Given this list of marker genes Nampt, Ralgapa1, Epha7, Pde6a, Zfp110, Icmt, Rhebl1, Stard8, Egf, Klk1b4, Arhgef3, Tlr2, Hesx1, Cxcl12, Ghrhr, Spag9, Flot2, Fbxo21, Ccl19-ps1, Dcn, Cysltr2, Taok3, Trim25, Hmga1, Gpr39, Fgd4, Ahr, Map3k10, Rock1, Tlr13, Fam83d, Gbp7, Rhov (ras homolog family member V), Myo9b, Mapk8, Fermt2, Trim55, Gbf1, Git1, Trim8, Capn1, Dock10, Cadm4, Usp25, Dnm2 (dynamin 2), Rhoc, Arhgef11, Cp, Erbb3, Tspan6, Saa3, Ikbkg, Tlr4, Rasal3, Men1, Prdm15, Car8, Arhgap33, Ankrd17, Gapdhrt2, Syngap1, Lingo1, D1Pas1, Myoz1, Adcyap1, Rtkn, Nfkbia, Cd40, P2ry12, Bmp7, Col6a1, Dstyk, Nenf, Adam17, Ift80, Nfkb1, Ripk2, Cd84, Pml, Egln1, Osm, Cth, Fgf17, Cd19, Fgfr4, Igf1, Mtdh, Eif2ak4, Fbp1, Xdh, Mid2, Pak6, Rapgef1, Fgf10, Hspb1, Gfral, Iapp, Sla2, Ptk2b, Epha2, Wnt7a, Avp, Mir290a, Pik3c2a, Dusp19, Hcst, Ksr1, Pea15b-ps, Irak2 (NCBI Gene Id 74787), Dgkq, Acvrl1, Kank2, Pidd1, Erp29, Cav1, Ppp3cb, Rala, Nlrp6, Rell1, Mir205, Lmnb1, Cntnap2, Ralgps2, Smad6, Cartpt, Ccr2, Hdac7, Olfm4, Ago1, Sharpin, Mir423, Nckap1, Ralgds, Inpp5f, Ercc6, Atf3, Tgfb3, Adgrg6, Rnd2, Tnfrsf19, Bmyc, Crkl, Nfkb2, Agt, Atad3a (NCBI Gene Id 71964), Tlr9, Kit, Selenok, Rab30, Trim12a, Zc3hav1, Tmsb4x, Fgf9, Prkar1a, Sct, Sfrp4, Ccr6, Tbc1d10c, Bmp4, Foxo1, Grm4, Nrxn1, Myo16, Ripk3, Pin1rt1, Fam89b, P2ry6, Park7, Naip1, Adora2b, Sdcbp (syndecan binding protein), Wdr72, Cactin, Lztr1, Arfgef1, Pxn (paxillin), Npr1, Ophn1, Ucn, Spry2, Traf3 (TNF receptor-associated factor 3), Araf, Ppp1r9b, Calcr, Stox1, Mapk9, Ralb, Ighm, Arhgef7, Srgap1, Slc39a8, Csk, Atp1a3, Gadd45g, Edn2, Rab33b, Ccl11, Gm266 (NCBI Gene Id 212539), Nrg1, Rab4a, Cripto, Ccdc88a, Capn3, Ddx3x, Mapk15, Rasgrf2, Itga3, Syk, Tnik, Nfatc2, Ccr10, Trim59, Pak3, Arhgap30, Ranbp9, Kdr, Dok4, Nqo2, Sh3rf2, C1qtnf4, Pde8a, Trpv1, Rfxank, Cul3, Grm1, Tle1, Kank1 (KN motif and ankyrin repeat domains 1, NCBI Gene Id 77823), Fxr1, Optn, Phb2, Rasgrp1, Pde6b, Nucb2, Eid2 (EP300 interacting inhibitor of differentiation 2), Ptbp1, Cbl, Bmp10, Nradd, Ajuba, Tob1, Cd160, Atp1b1, Lhcgr (NCBI Gene Id 16868), Il11, Map3k7, Pik3cb (phosphatidylinositol-4,5-bisphosphate 3-kinase catalytic subunit beta), Pik3r6, Gpr62, Ffar4, Atoh8, Ncald, Garre1, Lat, Mapkbp1, Zc3h12a, Serpine2, Eras, C3ar1, Chi3l1, Git2, Cops8, Naip6, Impact, Chrna10, Rilpl1, Mapt, Nup93, Arhgap8, Crhr2, Fbln1, Drd2, Rtn4r, Smad2, Sema7a, Styxl2, Sctr, Dact1, Hipk3 (homeodomain interacting protein kinase 3), Gstp-ps, Irf3, Farp2, Veph1, Cdc42, Pde1c, Ube2n, Alms1, Vcp, Eng, Cpne1, Shoc2, Chrm3, Iqsec3, Mir25, Fbxw7, Dock2, Il6, Ripor1, Gprc5b, Klrh1, Adra1b, Usp49 (ubiquitin specific peptidase 49), Eps8l2, Agr2, Dusp16, Jmjd8, Trim56, Sema3e, Axin1, Traf7 (NCBI Gene Id 224619), Ndrg2, Rell2, Mt1 (NCBI Gene Id 17748), Stk11, Pde4c (NCBI Gene Id 270056), Ptgdr2, Gnai1, Plekha1, Pkhd1, Nck1, Arhgap27, Plekhg5, Rac3, Cdc42ep3, Cxcr2, Fbxo8, Btbd10, Rap1gap, Irak3, Rasgef1a (NCBI Gene Id 70727), Pecam1, Smpd3, Plcb1, Dok2, Rcan1, Insl3, Fzd5, Mdfic2, Prok1, C1qtnf3, Rab3gap1, Lrrc19, Arhgef12, Rit1, Styx-ps, Cd28 (CD28 antigen), Bag4, Irak4, Tspyl5, Nck2, Ctnnb1, Klhdc10, Mydgf, Tgfb2 (NCBI Gene Id 98738), Rhog, Reg1, Vrk2, Ankrd26, Rsu1, Ptk2, Psd, Amh, Ank3, Trp53, Cmya5, Tbx1, Cilp, Ppp3cc, Gucy1b1, Azi2 (NCBI Gene Id 27215), Hcls1, Ndp, Abi2, Map3k3, Pdgfb (platelet derived growth factor, B polypeptide), Tnip1, Kif14, Rap1b, Rhof, Chp2, Ddr1, Pde3a, Gcn1, Cdc34, Nox1, Dyrk1a, Gucy1a2, Igtp, Timp2, Apoa1, Npy2r, Rhoh, Tnni3, Fos, Epor, Plk2, Nfkbib, Klhl31, L1cam, Fzd7, Cgnl1, Scg2, Cxcr5, Lmo3, Myoc, Sema6a, Myh9, Arhgdia, Dab1, Ambra1, Prkce, Adgrg3, Samd14, Prnp, Rnd1, Kbtbd2, Cd27, Mapk8ip3, Nr1h4, Ccl19-ps6, Gpbar1, Cap2, Itpr3, Ezh2, Grin2d, Arhgap42, Usp50, Rapgef6, Letmd1, Myd88, Mapk13, Ptpn11, Raf1, Pde5a, Nkx3-1, Pik3r1, Arhgap31, Scn11a, Dgki, Lpar3, Arfgef3, Hyal2, Adra2a, Wdr54, Sorbs3, Cib1, Hax1, Ccl19-ps3, Nherf1, Musk, Atp2a2, Baiap2, Rcn3, Mup2, Cited1, Csnk1a1, Map3k9, Mir185, Ucma, Rc3h1, Sh2b2, Trim26, Cd74, Psd2, Ros1, Pik3r3, Nrbp1, Fam3c, Fshr, Ralgps1, Rap1gap2, Qars1, Lat2, Map4k5, Npr2, Dusp9, Bmp5, Pde7a, Rem1, Tmem38a (transmembrane protein 38A), Ptpn2, Dusp13b, Irs3, Irag1, Pdk2, Ntsr2, Ppef2, Prr5l, Hmgb1, Arhgap22, Adgrb2, Fgb, Chml, Itgav, Kcnc2, Gal, Tnfsf10, Spatc1l, Fgr, Trim52, Esr1, Cyth4, Cdc42se2, Itpkb, Tbk1, Prdm11, Eif2s1, Dock7, Nkiras2, Mbip, Arhgap5, Lims1 (NCBI Gene Id 71899), Nlrx1, Map2k6, Ccl21b, Foxm1, Gdf11, Il6ra, Ryk, Gadd45b, Mfhas1, Ccr9, Mapkap1, G3bp2, Rnf149, Gps2, Erfe, Dele1, Efhb, Ndrg4, Rasgef1c, Nos2, Ntrk2, Smad7, Igfbp6, Pp2d1, Ndst1, Gba1, Mef2a, Huwe1, Terf2ip, F2rl1, Trem2, Usp20, Sh2b3, Dok3, Ppp2ca, Aim2, Relb, Tmem38b, Tab1, Igfbp4, Ngfr, Src, Ccl21e, Extl3, Adrb1, Crh, Fadd, Lyn, Rras2, Prkar2a, Tmbim4, Itpr2, Rhou, Bmp6, Atp2b4, Map4k1, Trim15, Ralbp1, Birc7, Mylk2, Tff2, Dok1, C1qtnf12, Cdc42bpa, Gucy2d, Dyrk2, Ern2, Akap12, Lrp1, Daxx, Malt1, Taar1, Rbpms, Rab39b, Ski, Sema4c, Apoe, Rln1, Akr1c18, Ceacam1, Paqr3, Gna13, Itsn1, Prxl2c, Cdon, Nfatc3, Rb1, Sos1, Met, Gsdme, Zfp36l2, Dnaja1, Card10, Jpt2 (NCBI Gene Id 69951), Sfrp5, Inhba, Thpo, Nod2, Hdac1, Inava, Tgfbr3, C1qtnf1, Csf1r, Dusp29, Cd81, Lbh, Ptger4, Wnk1, Mbp, Cap1, Gip, Rbx1-ps, Dhx15, Fzd10, Bcr, Ppm1a, Mcu, Igf1r, Gm527, Cxcr6, Wnk4, Fgf13, Treml1, Actn3, Blvra, Sh3bp1, Fhl2, Ppp3r2, Tab3, Dsc2, Rubcn, Drd5 (NCBI Gene Id 13492), Gper1, Spi1, Pdgfrb, Fgfr3 (NCBI Gene Id 14184), Pik3ca, Mras, Dock9, Fbxl2, Wasf2, Nppb, Pdgfd, Bmper, Xbp1, Brd4, Casq1, Zmpste24, Dusp4, Hdac3, Adora1, Ghrh, Ccdc125, Adipoq, Tnfaip1, Uso1, Ppia, S2bpcox16, Trim38, Bank1, Prdx2, Prmt5, Atf4, Grb10, Agtr2, Vegfa, Tfrc, Cryab, Nog, Cdc42se1, Mup5, Efna1, Pde1b, Sos2, Rapgefl1, Bcl3, Crnn, Rassf1, Pten, Cav3, Nod1, Madd, Wnt4 (NCBI Gene Id 22417), Traf6, Dab2ip, Lgals9, Ephb2, Dhx33, Cyrib, Grb2, Kl, Errfi1, Plaat1, Dusp7, Hpca, Gdf7, Ptpn13, Micall2, Fgf5, Nfatc4, Map3k11 (NCBI Gene Id 76541), Ccn3, Auts2, P2rx7, Wdr83, Hnf1a, Inppl1, Fkrp, Pde6c, S100a7l2 (NCBI Gene Id 403173), Mapk8ip2, Ccl20, Casq2, Tirap (NCBI Gene Id 117149), Gucy2f, Nop53, Pik3ap1, Unc5cl, Nron, Gstp2, Sbno1, Ppp1r9a, Dusp5, Mup1, Slc30a10, Cavin3, Igfbp3, Phlpp1, Stk4, Hpse, Dynlt1b, Nlrp12, Rasa2, Dab2, Gapdh-ps15, Lax1, Mup11, Traf4, Pth, Pcp4, Dgkz, Pik3r4, Rhod, Ltk, Actn4, Lmcd1, Cyth1, P2rx4, Il18r1, Eda, Specc1l, Ywhaq, Hfe, Ncam1, Arfgap1, Ccdc22, Arl6ip5, Mapk6, Dvl2, Garem1, Apip, Grik1, Mapk3, Mir130a, Atp2c1, Otud3, Adam9, Arhgef28, Pramel7, Homer2, Ptp4a3, Trim5, Mt3, Cacna1d, Dvl3 (dishevelled segment polarity protein 3), Trim67, Ccl19-ps4, Nlrc3, Map3k1, Ubd, Sox9, Trpm2, Pdgfa, Xcr1, Creb1, Dgkg, Prkd1, Bmp2, Abra, Fpr-rs3, Pik3r2, Ticam2, Sesn3, Defb37, Avpi1, Prkg1, Nfe2l2, Epgn, Rb1cc1, Tmbim1, Mapk14, Prkn, F2, Casp8, Rap2c, Mir382, Ikbkb, Dcc, Irgm1, Card6, C5ar1, Celsr1, Synpo2l, Ifi35, Mapk11, Ncor1, Zap70, Ccr7, Akap6, Plce1, Osbpl8, Lime1, Jak2, Hdac4, Trpa1 (transient receptor potential cation channel, subfamily A, member 1), Akip1, Irgm2, Tlr1, Hsf1, Col6a3, Uchl1, Arf6, Notch2, Pik3cd, Tprg1l, Adgrv1, Spred3, Gstp3, Map2k7, Plk3, Atf2, Erbb4, Mapkapk5, Zfp36, Ulk4, Ddit3, Mapk7, Ptpn1, Cxcr1, Mir143, Stub1, Nr1d1, Cdc42ep4, Oprm1, Becn1, Ins2, Nf2, Peli1, S100a13, Pde2a, Nyap1, Ppard, Cdk5rap3, Meis3, Stk40, Prkcd, Fyn, Ntrk3, Vegfb, Ephb1, Rap1gds1, Nr5a1, Nyap2, Prkch, Faim, Rhob, Mir744 (NCBI Gene Id 791070), Gdf6, Vrk3, Hras, Plxnb1, Dlg1, Gapdh (NCBI Gene Id 407972), Picalm, Pou4f2, Nup62, Pak2, Racgap1, Map3k2, Rhobtb1, Npnt, Ank2, Sfrp1, Arhgap1, Trp73, Kitl (kit ligand), Spred2, Tgfbr2, Pex5l, Gria1, Clec7a, Unc5b, Ilk, Lipa, Ntrk1, Fcgr2b, Usp10, Cd2ap, Pafah1b1, Sla, Clec4n, Rora (RAR-related orphan receptor alpha), Glce, Camk2d, Wdr91, Riok3, Avpr1a, Drd4, Pea15a, Prmt1, Map3k12, Dok5, Lilrb4b, Jun, Csf3, Dbndd2, Fpr-rs6, Mertk, Pde1a, Bst1, Prex2, Map1lc3a (NCBI Gene Id 68411), Rnf31, Rit2, Prkd2, Stk39, Rnd3 (NCBI Gene Id 99050), Rac2, Snip1, Pla2g2a, Sh3rf1, Gadd45a, Ern1, Ext1, Pim2, Apc, Guca2b, Ceacam2, Tgfb1, Stmn1, Cacna1c, Tlr3, Cep55, Exoc4, Arhgap35, Glp1r, Mapk1, Serpinf2, Wnt7b, Txn1, Col6a2, Pdcd4, Eps8, Wasf1, Arhgef9, Fas, H2-M3, Cyth2, Pdgfra, Itch (NCBI Gene Id 77732), Braf, Esr2, Rgs2, Ikbke, Acvr2a, Psmd10 (NCBI Gene Id 54172), Ccn2, Kndc1, Eif2ak3, Cntf, Edaradd (NCBI Gene Id 76354), Fgf1, Calr, Phlda3, Cxcr4, Ccl21a, Tnfsf14, Arfgef2, Lta, Gcnt2, Gucy1a1, Pla2g5, Asb3, C1qbp, Ndnf, Cdc42ep1, Grm5, Sphk1, Itgb3, Prkar1b, Net1, Lilra5, Rasal1, Slamf1, Fgf18, Arl3, Nbr1, Ccr5, Iqsec2, Htt, Rac1, Tlr7, Dkk1, Rap2b, Alkal1, Ret, Styx, Ripor2, Ywhae, Dock4, 3425401B19Rik, Pdpk1, Zdhhc17, Otud7b, Rab15, Nphs1, Necab2, Sfn, Vav2, Ptpn6, Jcad, Traf2, Slc8a2, Itpr1, Fgfbp3, Wwc1, Myc, Plvap, Ddx21, Pld2, Pebp1, Sbk2, Stambp, Ryr2, Arhgef2, Cracr2a, Card9, Angpt1, Ldlrad4, Fam110c, Mup3, Dennd4b, Epha4, Tyro3, Ryr3, Nelfe, Cd8a, Fgf21, Ccl21f, Tmem106a, Cdkn2a, Adrb3, Spink1, Mas1, Cav2, Adra1a, Cd4, Smad5, Arrb1, Pomc, Rhobtb2, Pde7b, Gdf15, Il1b (NCBI Gene Id 16176), Dusp10, Lpar1, Nrp1, Wnt5a, Eps8l1, Lilrb4a, Tpbg, Cbs, Adra2c, Igfbp5, Fpr2, Htr2a, Btrc, Kars1 (lysyl-tRNA synthetase 1), Fgf7 (fibroblast growth factor 7), Gpr3, Ren1, Adnp, Lamtor1, Tifa, Tns3, Defb1, Trat1, Parp1, Ptprr, Rasip1, Cnksr3, Lamtor5, Pik3c2g, Adra1d, Ppp2cb, Rela, Gdf5, Nppc, Fer, Col3a1, Phb1, Cdc42ep2, Abca1, Cavin4, Ccr8, Smad3, P2ry1, Fgg, Inpp4b, Birc2, Ddrgk1, Gapdhrt, Mir181d, Or2at4, Ptprc, Mmd2 (NCBI Gene Id 97274), Tiam2, Ufl1, Birc3, Rictor, Zfp91, Ccl21d, Arhgdig, Camta1, Erbb2, Tnk1 (tyrosine kinase, non-receptor, 1), Rapgef3, Rasa3, Sqstm1, Dag1, Mos, Ace2, Ssx2ip, Ccr3, Mdfic, Sptbn1, Aif1, Pde10a, Mst1r, Rasd1, Cblc, Nmnat1, Gpr37l1, Cyld (NCBI Gene Id 74256), Glipr2, Arhgap9, Gipr, Bmpr1b, Iqgap1, Gsn, Pde4b, Fgf12, Hspa5, Acta2, Arhgap28, Wnk2, Cherp, Sipa1l1, Dsg3, Kras, Alkal2, Flt4, Myoz2, Lurap1l, Sod1, Magi2, Ednra, Arrb2, Arhgef18, Ppp3r1, Ep300, Ccl19-ps5 (C-C motif chemokine ligand 19, pseudogene 5), Cops5 (NCBI Gene Id 98296), Npsr1, Fcer1a, Fkbp1b, Serpina12, Sema4d, Pycard, Shtn1, Nrk, Trim30b, Rap1a, Nlrp3, Abl2, Lrp4, Grin2b, Ralgapa2, Pde4d, Ednrb, Sesn1, Drd3, Ppm1n, Adora2a (adenosine A2a receptor, NCBI Gene Id 11540), Il3, Mturn, Pik3c3, Prkaca (protein kinase, cAMP dependent, catalytic, alpha), Pink1 (NCBI Gene Id 68943), Cx3cr1, Tifab, Lrp2 (low density lipoprotein receptor-related protein 2), Tmc8 (NCBI Gene Id 276788), Als2, Tmed2, Dok7, Traf1, Grap, Epo, Map3k19, Grik2, Stk38, Map2k1, Sash1, Gas6, Ece1, Psen1, Hdac2, Hcrtr1, Mir1a-2, Mecom, Myh7b, Il18, Ccr1, Qrich1, Pde3b, Dynlt1f, Stradb, Cdk10, Dusp6, Kcnj11, Grm2, Csf1, Map4k3, Arhgap20, Fbxw11, Tnfsf15, Pik3cg, Ncs1, Il34, Mstn, Rab33a, Mir7-1, Npffr2, Trim62, Map3k4, Gnai2, Map4k4, Ovol2, Kbtbd6, Rack1 (NCBI Gene Id 14694), Nek10, Trib1, Mcf2l, Agtr1a, Tpcn1, Csrp3, Psd4, Dock1, Sco1, Fgf4, Arhgap40, Kcnn4, Gpr37 (G protein-coupled receptor 37), Rc3h2, Tpd52l1, Ppp3ca, Rab12, Map2k3, Neurod2, Tnf, Nol3, Elmo1, Rtkn2, Nlk, Dynlt1c, Grem1, Fn1, Taok1, Rundc3a, Edar, Arhgap29, Rgn, Nkd1, Plcg1, Mir1a-1, Atg14, Ulk1, Mfn2, Cdc34b, Chga, Irak1bp1, Prkaa1 (protein kinase, AMP-activated, alpha 1 catalytic subunit), Trf, Arhgap25, Rpap2, Arhgdib, Arhgap45, Il1a, Nox4, Ptpn22, Pde6g, Dennd2b, Heg1, Magi3, Pja2, Pde9a (NCBI Gene Id 18585), Pik3c2b, Klf4 (Kruppel-like transcription factor 4 (gut)), Rassf2, Fnta, Smad1, Stard13, Dusp8, Rps23rg1, C1qtnf2, Nedd4, Bnip2, Calm3, E130311K13Rik (RIKEN cDNA E130311K13 gene), Rabl3 (RAB, member RAS oncogene family-like 3), Sipa1l2, F2r, Nmi, Zfp622, Marco, Pde8b, Itgal, Alpk1, Nmur1, Fgf20, Thbs1, Scai, Rhoq, Fgf16, Erc1, Bmpr1a, Hmgcr, Apela, Syde2, Rasa4, Tnip2, Taok2, Shc1, Arhgap32, Card14, Akt2, Grin2a, Ccdc88c, Tnfrsf1a, Mcoln1, Ralgapb, Nfix, Zeb2, Rasgrf1, Lin28a, Ccna2, Npy5r, Nts, Uaca, Rgl2, Dock8, Dhx36, Arhgap18, Mapk12, Adgrg1, Arhgef5, Homer3, D130043K22Rik, Ppp1r16b, Igf2, Slc8a1, Tbx20, Gria3, Ube2b, Dmpk, Ptger3, Kbtbd7, Mtor, Gpr55, Tlr8, Calm1, Cdkn1a, Arhgap19, Adra2b, Rasgrp4, Rxfp2, Guca1a, Mmp3, Edn1, Gstp1, Alox12b, Fgf6, Rheb (Ras homolog enriched in brain), Rab4b, Ccr1l1, Cdc42ep5, Clec4d, Fgfr1, Rhoa, Rgs14, Pik3ip1, Sirt3, Dhcr24, Fgf22, Pbk, Ezr, Nos3, Shank3, Smad9, Ppm1b, Tek, Ppara, Rock2, Hand2, Chuk, Dusp15, Negr1, Nr3c2, Apoc3, Lif, Rab39, Gna12, Cdh13 (cadherin 13), Camkk2, Ntn1, Fgf14, Bmpr2, Rdx, Prkca, Litaf, Nfam1, Havcr2, Crebbp, Cyth3, Cyfip1, Trim39, Plcd1, Tnfsf11, Trim12c, Muc20, Cd300a, Amfr (autocrine motility factor receptor), Runx2, Fgf2, Rasgrp2, Gpnmb, Rgl3, Rab9b, Mir7-2, Acvr1, Nos1, Spred1, Sema5a, Ube3a, Twsg1, Ins1, Rabgef1, Tpcn2, Frs2, Sox2, Epha5, Rhoj, Synj2bp, Gm14137, Gab2, Ghrl, Ltbr, Slit2, Ogt, Map3k21 (NCBI Gene Id 234878), Cabyr, Rapgef4, Psd3, Mapk8ip1, Calm2, Kiss1r, Stk19, Ccn1, Dbnl, Cmklr1, P2rx1, Bhlha15, Smad4, Gpr101, Arhgap44, Iqgap3, Them4, Atp6v0c, Ash1l, Ccr4, Nkiras1, Lox, Tmem100, Rel, Sgcd, Bok (BCL2-related ovarian killer), Mir504, Cyp19a1, Cd40lg, Ackr3, Gpr4, Ror2, Mir494, Zfp36l1, Akap13, Dock3, Xiap, Cryba1, Dusp22, Brk1, Alox15, Ksr2, Fgf3, Klb, Grik3, Lemd2, Sesn2, Arhgap12, Dlc1, Dmd, Vav3, Id1, Rps3, Mc1r, Sppl3, Tradd, Adipor1, Adcy8, Aida, Oxtr, Hbegf, Eda2r, Map3k14, S100b, Rasgef1b, Agap2 (NCBI Gene Id 216439), Ticam1, Nfkbid, Mef2c, Lurap1, Tpbpa, Atp6ap2, Selp, Psca, Nherf4, Ntf3, Pnma5, Arhgap17, Tlr6, Rapgef2, Eif3a, Lamtor3, Gpr183, Tsc2, Sh2d3c (SH2 domain containing 3C), Dipk2a, Wwtr1, C3, Rcan3, Trpv4, Ctsh, Lrrk2, Stat1, Rab35 (NCBI Gene Id 77407), Gna15, Tgfa, Irs2, Ago3, Kctd13, Gucy1b2, Cat, Irf1, Grin1, Amot, Mt2, Mul1, Flcn, Rabif, Atf1, Dixdc1, Dennd1a, Gabarap, Sirt7, Pik3r5, Naip2, Tgfbr1, Rufy1, Ltb, Oma1, Zmynd11, Kcnj8, Nf1, Trip6, Tox3, Abcc2, Mtm1, Mapk4, Tcf7l2, Gab1, Ddr2, Map3k6, Scimp, Flot1, Cd86, Hgf, Traf3ip2, Trim44, F11r, Bcl6, Adora3, Traf5, Adrb2, Mid1, Defb25, Spry1, Arl6, Fpr-rs4, Dennd4c, Tax1bp3, Fgf23, Map3k5, Ndufc2, Grap2, Sh2b1, Sstr4, Fpr-rs7, Icam1, Lamtor2, Rab9, Rps6ka6, Zfand6, Garnl3, Tnfrsf11a, Ctnnal1, Maged1, Pbp2, Plcg2, Gpx1, Cckbr (cholecystokinin B receptor), Map4k2, Naip5, Gcg, Cass4, Cdh2, Emilin1, Bcl10, Mir181c, Rnf13, Rtn4, Cd44, Prag1, Nodal, Pdcd10, Zmiz1, Cspg4, Cxcr3, Dnaja3, BC028528, Ripk1, Ramp3, Htr2c, Map2k2, Dusp1, Marveld3, Trim60, Fzd8, Adcy2, Card11, Aqp1, Map3k13, Ccnq, Rnf41, Dock11, Rbck1, Insr, Kiss1, Siglecg, Akt3, Nisch, Cd36, Sipa1l3, Htr2b, Lep, Hmox1, Laptm5, Orai1, Trim32, Atf7, Pdgfc, Ppp2r1a, Obscn, Cxcl17, Tnfaip8l3, Agrn, Gata3, Dock5, Lrrc25, Sphk2 (NCBI Gene Id 97350), Ywhaz (tyrosine 3-monooxygenase/tryptophan 5-monooxygenase activation protein, zeta polypeptide), Prkcz, Abl1, Sfrp2, Cgas, Trim30d, Nr2c2, Ngf, Pkia, Axl (AXL receptor tyrosine kinase), Pabpn1 (NCBI Gene Id 54358), Frmd7, Lpar2, Fgf8, Cd3e, Drd1, Map2k5, Pros1, Rbx1, Nfat5, Ackr4, Nppa, Cx3cl1, Nptn, Tank, Pde4a, Slc9a1, Ager, Nfkbil1, Trim30c, Itgb1bp1, Ankrd1, Nherf2, Flna, Eif2ak1, Casr, Ccrl2, Casp1 (caspase 1), C1ql4, Akt1, Psap, Sgsm3, Fgd2, Prkcb, Sipa1, Mkrn2 (NCBI Gene Id 97310), Ube2i, Ddx1, Prr5, Abcc9, Stat3, Arhgap15, Cnksr1, Prl, Nr5a2, Oprk1, Fzd4, Tmem33, Iqsec1, Map3k20 (NCBI Gene Id 99253), Il1r1 (interleukin 1 receptor, type I), Mdfi, Ppm1l, Asb15, Inpp5e (inositol polyphosphate-5-phosphatase E), Fem1a, Rgl1, Pparg, Dynlt1a, Dennd3, Sirpa, Slc24a4, Sh3rf3, Mtnr1b, Col1a2, Stk3, Myorg, Cd22, Npy, Pak1, Dusp3, Fgf15, Trim30a, Tgm2, Eif2ak2, Notch1, Gsk3b, S100a4, Edn3, Phactr4, Avpr1b, Ada, Nucb1, Usp8, Pmepa1, Bnip1, Ccl3, Tnip3 (NCBI Gene Id 414084), Reln, Cflar, Myo18a, Aplnr, Crhr1, Gucy2e, Per1, Ugt1a1 (NCBI Gene Id 394436), Fgfr2, Gdi2, Mgrn1, Itga1, Ror1, Chrna7, Ccl5, Robo1, Chp1, Adcyap1r1, Mapkapk2, Itgb1, Rasgrp3 (RAS, guanyl releasing protein 3), Rcan2, Lepr, Map2k4, Eps8l3, Twist1, Stk25, Vangl2, Trim13, Pde6h, Mup4, Rap2a, Wnt16, Csnk2b, Tab2, Adissp, Pear1, Ankrd6, Tiam1, Prdx1, Mif, Was (Wiskott-Aldrich syndrome), Adam8, Oprl1, Ryr1, Mapk10, Dusp2, Ar, Abca7, Nras, Rras, Pdcd6, Dgkd, Pln, Rhbdd3, Trpm4, Ccl19, Pdpn, Ltf, Clcf1 (cardiotrophin-like cytokine factor 1), Rasd2, Rapgef5, Prkar2b, Inpp5k, Rab21, Vav1, Pak5, Pak4, Tagap, Ptprj, Sirt1, Gmip, Tnfaip3, Tnxb (tenascin XB), Fktn, Map3k8, Farp1, Akap5, Hrh4, Gdf2, Arhgap24 (Rho GTPase activating protein 24), Dnajc27, Epha8, Agtr1b, Egfr, Dusp26, Mapre2, Crk, Hipk2, Dock6 (NCBI Gene Id 76780), Map3k15, Ackr2, Gdi1, Flt1, Btn2a2, Tcim, Tenm1, Spry4, Nfatc1, Irak1, Cdk2, Chrna9, Pkd2, Irs1, App, Bcar3, Dennd4a, Syde1, Fasl (NCBI Gene Id 14103), Stmn3, Kctd10 (NCBI Gene Id 97265), 4930544G11Rik, Cd24a, Brap, Pde11a, Hacd3, Smpd1, Chm, Cul1, Mink1, Chn1, Fga, Plcd4, Peli2, Hint1, Pin1, Maz, here is a description of the gene set: An intracellular signaling module that is part of larger signaling pathways that can be initiated either intracellularly or by cell surface receptors. Intracellular signaling cassettes are discrete signaling units that are often shared by multiple signaling pathways. studied in species Mus musculus Mouse Gene Set: GOBP_INTRACELLULAR_SIGNALING_CASSETTE